The following is a description of a gene set: Human Gene Set: BUSSLINGER_DUODENAL_EC_CELLS from publication Busslinger GA, Weusten BLA, Bogte A, Begthel H, Brosens LAA, Clevers H (PMID 33691112) species: Homo sapiens, and this is the list of marker genes: ADH4, TTR, MS4A8, PCSK1, TIMP1, ADGRG4, DDC, CRYBA2, ID1, TFF3, SPINK1, CHGA, CES1, RGS2, MAP1B, CADPS, KCTD12, LCN15, PCSK1N, IGFBP3, FEV, SCGN, CHGB, SCG2, NEUROD1, RAB3C, CDHR3, SCT, GC, REG4, PCSK2